The following is a description of a gene set: Human Gene Set: GOBP_POSITIVE_REGULATION_BY_HOST_OF_VIRAL_PROCESS A process in which a host organism activates or increases the frequency, rate or extent of the release of a process being mediated by a virus with which it is infected. studied in species Homo sapiens, and this is the list of marker genes: TBC1D20, ZDHHC20, STOM, YTHDC2, ZNF502, EEF1A1, ZDHHC9, NUCKS1, CSF1R, PAIP1, PIK3C3, PC, CFL1, VAPA, VAPB, IGF2R, ZDHHC8, ZFYVE1, PPIB, CAV2, APOE